The following is a description of a gene set: studied in species Mus musculus Mouse Gene Set: GOBP_TUBULIN_DEACETYLATION The removal of an acetyl group from tubulin. An acetyl group is CH3CO-, derived from acetic acid., and this is the list of marker genes: Tada3, Tppp, Mbip, Prkaa1, Tada2a, Ep300, Bex4, Fry, Kat14, Flna, Bex6, Nek3, Mapt, Prkaa2, Kat2a, Yeats2, Hdac6, Zzz3, Sgf29, Fnta, Sirt2, Dr1, Wdr5